Given this list of marker genes HLA-DRB1, FAS, SLC39A14, NLRP3, FGFR2, PTPN22, NHP2, TINF2 (NCBI Gene Id 26277), CYP1B1, COL17A1 (NCBI Gene Id 7828), NOP10, NDP, KRT3, ATOH7, MYOC (myocilin), PRNP, DKC1, GNAQ, TEK, IGSF3, TYMS, TACSTD2, KRT12, OVOL2 (NCBI Gene Id 8197), SREBF1, FZD4, SEMA4A, PARN, FGF10, SDHD, FGFR3, LTBP2, LRP1, here is a description of the gene set: Abnormally increased lacrimation, that is, excessive tearing (watering eye). Epiphora studied in species Homo sapiens Human Gene Set: HP_EPIPHORA